The following is a description of a gene set: species: Homo sapiens We demonstrate that the G protein Gi3 is the cellular target of the adenosine A3 receptor (A3R). By using a cell permeable peptide comprising the C-terminal end of Gαi3 fused to an importation sequence (ALL1) as a selective inhibitor of Gi3 signaling, we show that by coupling to Gi3, the A3R stimulates multiple signaling pathways in human mast cells, leading to upregulation of cytokines, chemokines and growth factors.Following contact with activated T cell membranes, endogenous adenosine binds to and activates the A3R, resulting in Gi3-mediated signaling. Specifically, the majority of ERK1/2 signaling initiated by contact with activated T cell membranes, is mediated by Gi3, giving rise to ALL1-inhibitable cellular responses. These results unveil the physiological GPCR that couples to Gi3 and establish the important role played by this G-protein in inflammatory conditions that involve adenosine-activated mast cells. We used microarrays to detail the effect of ALL1 on gene expression of HMC-1 cells activated directly by the A3 receptor, or by contact with activated T cell membranes. Genes down-regulated in HMC-1 (mast leukemia) cells: untreated versus incubated with the peptide ALL1. Human Gene Set: GSE19888_CTRL_VS_A3R_INHIBITOR_TREATED_MAST_CELL_DN from publication Baram D, Dekel O, Mekori YA, Sagi-Eisenberg R (PMID 20190146), and this is the list of marker genes: GKAP1, NBR1, DMXL2, TMT1A, NAMPT, OGFRL1, DUSP1, TET2, YPEL4, UNKL, TSPYL1, HECA, TSC22D2, FCRL3, PNPLA8, BACH1 (NCBI Gene Id 571), CALCOCO1, PELI2, AVPI1, GPR183, PIK3IP1 (NCBI Gene Id 113791), MED13L, ATP2B1, CREBRF, MARF1, TNFAIP3, FOXO3, THEMIS2, ZNF565, TGIF1, ZNF827, ABCB1, IDS, ZCCHC14 (NCBI Gene Id 84995), BEX3, SETD1B, SIRT1, KLF3, FBXL20, DACH1, TANC2, BCL6, NCF2, ZFYVE16, TMEM260, NLRP3, C9orf72, USO1, LAPTM5, PLXND1, ATP8A1, KMT5B, PPBP, HCAR3, N4BP2L2, ZNF211, SLC26A11, CTDSP2, ERBIN, LCDR, ZFP36, ZSWIM6, HSPBAP1, PICALM, ATXN7L1, TRA2A, ZBTB44, CLK4, C15orf48, BTG1, YPEL3, PDE3B, RNPC3, UBE2E1, SORL1, APLP2, ARID5B, PNRC1, MGAM, RNF11, YPEL5, RALA, CEP350, CXCR4, LINC01560, JMY, DUSP22, THBS1, RGS2, PFDN5, PIAS2, RB1CC1, ARAP1, PLAUR, SERINC1 (NCBI Gene Id 57515), CREBBP, TAPT1-AS1, STMN3 (stathmin 3), PPP4R3B, MIR101-1, FRAT1, EPHA4, SIK3, EFHC1, TNFRSF14, AKT3, RRN3P2, UBL3, HBP1, RAB11FIP2, ZNF106, ZEB2, LCOR, MIA2, KYNU, PSMA3-AS1, RESF1 (NCBI Gene Id 55196), DCAF8, PCMTD1, ZBTB18, UBN2, NR1D2, MARCKS, BOD1L1, ST6GAL1, PNISR, TCP11L2 (t-complex 11 like 2), F2R, TSEN34, GNS, FCHO2, ZFYVE1, ZBTB17, ERO1B, PAN3-AS1, DLGAP1-AS1, KDM7A, NSD1, CCPG1 (cell cycle progression 1), ITGB1, ZBTB10, UBXN6, FTH1 (ferritin heavy chain 1), RAB21, CCR7, OTUD1, HEXIM1, LINC02035, ZNF354A, ABTB1, SLC43A2, HLA-DRA, ZC3H12C, RPS11, SRGN, VEZF1, SRPRA, HBB, FAM228B, TP53INP1, RABEP1, FRY, NF1, CSTA, BAZ2B, SMIM14, TPD52L2, ARRDC2, FTH1P5, PLAAT4, TRIM23, RPL38, WASL, WDR45, PCMTD2, CXCL8, IFNGR1, MED13, SOCS5, NBPF10, ZNF638, G0S2, ZBTB20, TCF7L2, NAA50, IL7R, ZNF217, UBXN7, ZMYM2, ADM, ATP2B1-AS1, CAMK1D, PELI1, PAIP2, EPM2AIP1 (EPM2A interacting protein 1)